The following is a description of a gene set: species: Homo sapiens Human Gene Set: GOBP_CELLULAR_RESPONSE_TO_GLUCOCORTICOID_STIMULUS Any process that results in a change in state or activity of a cell (in terms of movement, secretion, enzyme production, gene expression, etc.) as a result of a glucocorticoid stimulus. Glucocorticoids are hormonal C21 corticosteroids synthesized from cholesterol with the ability to bind with the cortisol receptor and trigger similar effects. Glucocorticoids act primarily on carbohydrate and protein metabolism, and have anti-inflammatory effects., and this is the list of marker genes: SERPINF1, FLT3, ANXA1, GSK3A, HMGCS2, USP8, METTL21C, DDIT4, JAK2, EIF4E, MT-ND3, MYOD1, STC1 (stanniocalcin 1), SSTR4, BMI1, TGFB1, CFLAR, NPAS4, EDN1, ABCB1, BCL2L11 (BCL2 like 11), FECH, ZNF764, ETNPPL, ATP5F1A, ZFP36, SRD5A1, CRH, SMYD3, ZFP36L1, UBE2L3, CASP9, NR3C1, ISL1, FAM107A, KLF9, CBX3, ZFP36L2, TBX2, REST, TFAP4, ERRFI1, ASS1, FBXO32, SSTR2, PCK2, AQP1, FOXO3, HNRNPU, RPS6KB1 (NCBI Gene Id 6796), MSTN, GSTP1, AXIN2, PCK1, SSTR5